Given this list of marker genes TRIM14, GBP3, SIRPB2, TFRC, MSX1, ZMYND15, SMG1P3, PAMR1, CSGALNACT2 (NCBI Gene Id 55454), ELK4, ZPLD1, DRAM1, CYP27B1, KLF6, C6orf62, UBASH3B, BMAL2, ELOVL7, FERMT1, BMP2, UGDH (UDP-glucose 6-dehydrogenase), IRF1, KRT34 (keratin 34), APOL6, HYCC2, BLZF1, GBP5, SLC39A10 (NCBI Gene Id 57181), DUSP4, RICTOR, G0S2, IL15, IL24, NFE2L3, PTAFR, SGMS2, NMI, IL6, CXCL2 (NCBI Gene Id 2920), SPSB1, PABIR3, RAPH1, FOXN2, PANX1, ANTXR2, DCLRE1C, LRATD2, HSD11B1, RAB8B, THEMIS2, ARK2N, CXCL3, SHC4, CCNA1, ATP10A, NFKBIZ, CYP2J2, TDRD7, NPC1 (NPC intracellular cholesterol transporter 1), SPRY2, CFLAR, ERG, PLAAT4, NLRC5, ZC3H12C, LNPEP, GBP2, XRN1, EIF5, DAPP1, PARP12, MOB3C, NCOA7, SMURF2, FMR1, BIRC3, SREK1IP1, PDK4, LAP3, DUSP1, TMEM62, FST, SNORA3A, TRIM21, PTK2B, TLR2, SCG5, CPEB2, QKI, ADA2, GCNT4, RGMB, WNT10A, KDM7A-DT, ZNF800, NRCAM, PODXL, CMTR1, PNPT1, IL15RA, SOCS3, ZNFX1, TGFA, GPAT3, NKX3-1, IL23A, EDNRA, SLFN5 (NCBI Gene Id 162394), ETS1, KRT8, RNF19B, TMEM229B, SKIL, MALT1, ANGPTL4, TRIM38, SDC4, SEMA7A (semaphorin 7A (JohnMiltonHagen blood group)), PMAIP1, NCALD, IL13RA2, PCGF5, TRIML2, TOR1AIP1, NAV3, SAMD9, GNB4, TNFSF15, LMO2, SAMD8, B4GALNT2, MCTP1, IL1A, LYSMD2, DUSP2, MMP13, PDCD1LG2, RPPH1, RO60, APOBEC3F, MED13, C1R, STARD4, PLSCR1, PSG5, LEPR (leptin receptor), ITGA2, NMNAT2, NT5E, CTSS, TMEM106A, BCL2A1, EHD4, C17orf67, SERPINB9, ESM1, HAS2, EXOC3L1, TMEM217, ZBED6, GBP1 (NCBI Gene Id 2633), PLAUR, TENT5A, SHFL, IGFBP3, SLC7A11, SP140L, TNFSF10, EDN1, STAT2, STARD5 (NCBI Gene Id 80765), SLC25A28, ENPP4, PHLDA1, USP12, USP18, SOD2, BEND3P3, STBD1, BACH1, MUC16, MATN2, HCAR2, CXCL8, MAFF, MX1, FEM1C, RDUR, AIM2, PTPRE, SP100, FAS, PGM2L1, DTX3L, EDIL3, EIF2AK2, SAMD9L, TXNRD1, WNT9A, IL6ST, PDZD2, TAP2, CEMIP2, SPOCD1, CYFIP2, LCP1 (lymphocyte cytosolic protein 1), ZCCHC2, NECTIN3, RPLP0P2, RASA2, IL1R2, NUDCD1, MMP3, CCNG2, PLAT, SYNJ2, ADAR, LRRC3, SLC41A2, BMPR2, GDF15 (growth differentiation factor 15), CSF2, SYT12, SLFN11, NOCT, RIMS2, CDK17, FSD1L, SMG1P1, KIAA0040, CNTN3, REPS2, ANKRD12, IRF2, KCNQ3, KRT75, SLC10A6, ZNF107 (NCBI Gene Id 7660), HEPHL1, IFIH1, UCA1, ATP13A3, FYB1, KDM7A, DDX60L, RIGI, AIDA, C3orf52, LMF1, CAB39, RTP4, IFIT3, B3GNT7, CORO2B, TMEM47, OAS3, INHBA, OGFR, VEGFC (vascular endothelial growth factor C), TRIM25, APOBEC3A (apolipoprotein B mRNA editing enzyme catalytic subunit 3A), SAMHD1, TRAF3IP3, ARHGAP29, THBS1, DDX3X, CDCP1, SEC24A, NT5C3A, PML, GPR180, STK17A, GNAT2, HELZ2, TMEM158, CSF1, REC8, MIR614, BIRC2, IFIT5, TNFRSF10A, RBM43, ARL14, OSMR, CLDN1, CADPS2, SNORD17, ROCK2, SLC2A12, ADAMTS1, APOD, TAGAP (NCBI Gene Id 94011), RELB, DCP1A, RIF1, DHX58 (NCBI Gene Id 79132), BATF2, SOCS1, NRG1, RASGRP3, STAT5A, MYD88, WFDC2, RNASE7, FGF5, C1S (NCBI Gene Id 716), HCAR3, CLDN16, TAP1, CNP, TMEM140, HSH2D (hematopoietic SH2 domain containing), TRIM5, TRPV3, UBXN2A, BTC, MAN1A1, PLD5, MLKL, GLRX, ACE2 (angiotensin converting enzyme 2), SP110, IFI16, ANKRD1, LINC-PINT, HIPK3, BPGM, PLEKHA4, IL7R (interleukin 7 receptor), C3, XAF1, IRF9, HBEGF (NCBI Gene Id 1839), ITGA1 (NCBI Gene Id 3672), GSDMD, PPP2R2B (NCBI Gene Id 56686), RP2, N4BP1, KCTD12, CSRNP1, RELL1, CTSO, IDO1, ADAMTS6, H3-5, CARINH, PSORS1C3, SOWAHC, CD274, RASSF8, ATP6V0A4, APOBEC3G, SLC16A4 (NCBI Gene Id 9122), PARP9, ARL5B, IFIT1, TNFAIP3, GALM, CASP7, TGM2, TRANK1, AXL, PHF11, TRIM56, PTGS2, SDK1, WIPF1, ERAP2, IFIT2, ZBP1, CREB5, NIPAL1, ABCA1, APOL2, HS3ST2, IL16, UBA7, ADRB2, here is a description of the gene set: Genes up-regulated on treatment of normal human bronchial epithelial cells with beta interferon (hIFNB treatment 100u/ml, 4-12hrs). Analysis of the transcriptional response to SARS-CoV-2 compared with other respiratory viruses, including MERS-CoV, SARS-CoV-1 (SARS), human parainfluenza virus 3 (HPIV3), respiratory syncytial virus (RSV), and IAV. from publication Blanco-Melo D, Nilsson-Payant BE, Liu WC, Uhl S, Hoagland D, Møller R, Jordan TX, Oishi K, Panis M, Sachs D, Wang TT, Schwartz RE, Lim JK, Albrecht RA, tenOever BR (PMID 32416070) studied in species Homo sapiens Human Gene Set: BLANCO_MELO_BETA_INTERFERON_TREATED_BRONCHIAL_EPITHELIAL_CELLS_UP